The following is a description of a gene set: studied in species Mus musculus Mouse Gene Set: ETV2_TARGET_GENES from publication Yevshin I, Sharipov R, Kolmykov S, Kondrakhin Y, Kolpakov F (PMID 30445619) Genes containing one or more binding sites for (Etv2) in their promoter regions (TSS -1000,+100 bp) as identified by GTRD version 20.06 ChIP-seq harmonization., and this is the list of marker genes: Med18, Gm3364, Serpinf1, Brix1, Necap2, Parp3, Apold1, Gm16046, Rpsa, Ints11 (integrator complex subunit 11), Trip12, Ptges3l, Ebna1bp2 (NCBI Gene Id 97170), Dbt, Sympk, Uso1, Avl9, Snrpb, Ifnar1, Ing4, Tada3, Mier1, Dusp6, Gm26670, Myl12a, Mettl6, Garin1b, Topbp1, Rps6ka2, Fli1, Tln1, Efcab7, Amz2, Mcm8, Vamp3, Fem1a, Scrib, Mettl3, Cog2, Gm16120, Shroom3, 6030443J06Rik, Rnf216, Gm20716, Dnajb6, Prpf19 (pre-mRNA processing factor 19), Psma6, Rab13, Dhx36, Gm12694, Lamtor1, Mcrs1, Gm14010, Dph3, Clca2, Sowahc, Fkbp1a, Zranb2, Tex10, Med30 (NCBI Gene Id 70303), Zfp787, E2f4, Ngrn, Nup214, D330041H03Rik, Mon1b, Mfsd5, Ncbp2as2, Fmc1, Rpl36al, Clint1, Epn1 (NCBI Gene Id 13854), Pomp, Sox17, Oxnad1, Gm16104, AA474408, Pde4b, Vpreb1a, Mgat2, Trappc14, Sec24c, Ppan, Slc38a10, Pin1, Fam204a, 9330151L19Rik, Kcnk2, Dynlrb2, Tank, Ppp4c, 1600012H06Rik, Rab10os, Adprm, Wdr89, Spink10, Synj2bp (NCBI Gene Id 28115), Fam32a, Eaf1, Exd2, Sp2, 6530401F13Rik, Tufm, 2310011J03Rik, Cyb5d2, Slc15a4, Gm38250, Tmem126a, Traf7, Med11, Ypel3, Sirt6, Srd5a3, Mysm1, Sde2, Pex12, Rac1, Birc6, Fndc11, Arpc4, Ptdss1, Chmp5, Nsun5 (NCBI Gene Id 215084), Nelfe, Med17, Nosip, Ddx46, Zbtb45, Creb3, Pofut2, St6galnac3, Arhgap1, Wdr11, Trmo, Gnpat (NCBI Gene Id 51942), Zc3h15, Cds2, Fbxl9, 4933427D14Rik, Dok4, Rrp9 (NCBI Gene Id 27966), Calm3, C230035I16Rik, Kpnb1, Orc5, Atp6v1g2, Zfc3h1, Ndufaf7, Pcdh12, Lrrc75a, Ccdc181, Cass4, Txndc17, Rapgef6, 2810004N23Rik, Gm9828, Dpm1, Mcm7, Pik3r2, BC035044, F2rl3, 1700086O06Rik, Zfp110, Rasgrp3, Gm29328, Mroh8, Pdcd2, Top3b, Dusp3, Asb6, Ube3c, Rnpc3, Trmt11, Zbtb9, Gm15559, Ddx21, Gm1604a, Oard1, Nckap1, Etv2, Gtf2ird2 (NCBI Gene Id 114674), Pigx, Zzef1, Ctsh, Aste1, Sh3bp5, Ccdc51, Ric8a, Stk11ip, Trim41, 1500015A07Rik, 1810041H14Rik, Rraga, 1700054K19Rik, Pih1d2, Ciao2b, Trpm8, Pced1a, 4930592C13Rik, Sec31a, Ppid, Taf12, Exoc3, Zfp113, 4833420G17Rik, Nfkbil1, Lyset, Mrpl57, Prkar1a, Vps16, Pum3, Tatdn1 (TatD DNase domain containing 1), Aurka, C330018D20Rik, Rpl34, Gcc2, Fam124b, Tbc1d15, Ipo11, Copa, Hyal2, Bbs4, Fam110a, Etohd2, Noc3l, Pop7, Srsf7, Rbsn, Spopl, 4930478M09Rik, Fbxl12os, Ift70a2, Cox17, Mogs, Bcap31, Bcl6b, Moap1, Tek, Zfp865, Tlnrd1, Lrrc8a, Thoc5, Junb, Ttc39d, Usp45, Nkiras1, Arl15, Rchy1, Mttp, Rps6, Zfp143, Gm16096, Grpel2, Med10, Mrps16, Sec23ip, 4933417C20Rik, Ssbp1, Slc25a32, Ercc3, Cfap45 (NCBI Gene Id 71870), 2900076A07Rik, Ccnl1, Abcd1, Stk16, Wnt3, Cnrip1, Id3, Use1, Ncbp2, Slx9, Ncstn, Kif3b, Snrpe, Picalm, Yipf3, Col11a2, Gm26535, Ulk4, Myct1, Carf, Dele1, Elavl1 (NCBI Gene Id 97501), Snord15a, Glrx5, Cdk7, Rab11fip4os1, Mesd, Stk40, Gm11454, Cdk20, Ppp1r11, Gmip, Sema6b, Nfya, Prdm4, A330035P11Rik, Zc3hav1, Nsrp1 (NCBI Gene Id 237859), Cebpz, Arb2a (NCBI Gene Id 72538), Lsm5, Tmem154, Tnfrsf9, Hnrnpf, Sh3tc1, Ppp1r10, Pik3ca, Ccdc9, Rars1, Pex6, Gm25541, Nup107, Hjurp, Exoc2, Fth1, Psmd12, Mapk1ip1l, Cnbd2, Ephb4, Atxn7l1, Mmgt2, Hibch, Psen1 (presenilin 1), 2810021J22Rik, Ica1, Trmt10a, Tstd3, Sco1, Ddx18, 9230114K14Rik, Fdx2, Zcchc9, Cdt1, Sbno2, Wdr73, Ywhab, Snrpd3, Qng1, Rpl11, Ddx19b, Rpl37, S2bpcox16, Lrrc41, Smg7, Txnip, Pigm (phosphatidylinositol glycan anchor biosynthesis, class M), Ncdn, Ppm1g, Midn, Zfp558, Lpp, Cant1, Wrap53, Ctla2b, Zfp687, Fbxw2 (NCBI Gene Id 77009), Ndufb9, Catsperg1, Mir8098, Ggnbp1, Cnot10, Tmem229b, Tns2, Rps3 (NCBI Gene Id 52418), Rasip1, Rps27, Cog8, Gm10575, Gm12976, Itpa, Cage1, Gm15518, Ap2b1, Mocs3, Camkmt, Pak1ip1, Zfp407, Chd9, Bola2, Setd4, Crem, Dpm3, Gm26205, Zhx3, Slc9a8, Sugct, Dad1, Fbxl12, Tbpl1, Trib1, Rpn2, Cnr2, Esam, Tnpo3, Wipi2, Gm5447, Jak3, 1700082M22Rik, Coa5, Cltc, Cep41, Zfp7, Zfp57, Skic2, Zfp512, Snhg6 (small nucleolar RNA host gene 6), Zfp175, Psmd2, D5Ertd605e, Foxa3 (NCBI Gene Id 15377), Tmem208, Myl12b, Exoc3l, Tmem131l, Armc7, Atp1b3, Lncenc1, Prkab1, Ube2j2, Utp3, Ssmem1, Zfp623, Dnajc25, Dcaf13, Clta, Tcea1, Mrpl52, Uqcrh, AU040320, Itgb1, 1810014B01Rik, Itprid2, Diaph1, Itpripl2, Dbnl, Klhl6, Ap1b1, Crip2, Nek11, Iscu, Itgb3bp, Rpl27, Dtymk, Shc1, Gm37896, Gm15417, Nkapd1, Gm14167, Cracr2b, Lyrm2, Nmbr, Thap6, Zfp622, Tm9sf2 (transmembrane 9 superfamily member 2), Mir423, Grcc10, Ndufs3, Llph, Zfp105, Serinc5, Gle1, Tjp1, Trmt6, Tbrg4, Ttc9c (tetratricopeptide repeat domain 9C), Fbxo22, Zfp384, Polr1c, Tma7, Zfp24, Nelfb, M6pr, Fdxr, Vta1, Elf2, Tpm3, Tprkb, Tgfbr2, Hmgxb3, Cstf1, Bet1l, Ufm1, Ankrd24, D430040D24Rik, Prrg2, Gm10941, Khdc4, Usp28, Stk4, Ep400, P4hb, Ubac2, Washc1, Cdh5, 1700010I14Rik, Wdfy2, Susd1, Ttpal, Septin10, Pramel12, Mrps18b, Rapgef3os2, Adam17, Kdm5a, Atg16l1, Kcne3, Aim2, Rad1, Gamt, Cfap97d1, 4930405N21Rik, BC043934, Gm6410, Bnip3l, Ttc1, Ppib, Imp3 (IMP3, U3 small nucleolar ribonucleoprotein), Nat8f1, Eapp, Aco2, Isy1, Uba7, Evi5, Cfap57, Txndc5, Ap2a1, Atp6v0d1, Arih2, Gm19721, Eif5a, Tmem94, Emc7, Accs, Nip7, Arap3, Ubl5, 2310010J17Rik, Fhit, Lfng, Isca1, Rps19 (ribosomal protein S19), Idh3b, Tmem198, Btf3, Mterf3, Aggf1, Fubp3, Epha2, Stpg2, Tsr1, Csnk1g1, Mob3c (MOB kinase activator 3C, NCBI Gene Id 100465), Nfx1, Zfp330, Kti12, Tmem209 (transmembrane protein 209), Sptlc2, Glb1l, Cript, Acbd5, Exoc1, Ghdc (NCBI Gene Id 80860), Gm9917, Ywhaz, Phf5a, Zbtb17, Ankhd1, 1700020M21Rik, Vps4b, Slc43a2, Mplkip, Gabpb1, Tbkbp1, Igfbp4, 2410002F23Rik, Shoc2, Zfp568, Chpf, Zfp58, Ppp2r3d, Gale, Usp8, Snx11 (sorting nexin 11), Commd5, Sfr1, Prepl (NCBI Gene Id 77396, prolyl endopeptidase-like), Dnai4, Ttyh3, Rps17, Slc13a1, Arhgap27, Tmem258, F730311O21Rik, Tfam, Zfp408, Gm9967, Dapk3, Clic1, Sys1, Appl2, Cdk1, Gtf3c4, Nol6, Ttll1, Bag1, Gm15441, Rgs3, Gm10433, Cacybp, Grk5, Stat6, Tprg1l, 1700012E03Rik, Ocel1, Spty2d1, Cops7a, Mef2c, Trappc6b, Fen1 (NCBI Gene Id 14156), Fev, Prkag1, Gpatch2l, Ublcp1, Prex1, Tgif2, Gucd1, Champ1, Rhoj, Mrpl1, Rpl15, Cep19, Morn1, Vwf, 4930481B07Rik, Rapgef3, Hhex, Rundc1, Ube2f, 5730471H19Rik, Mirt1, Wdr12, Lhfpl7, Alg12, Tssk6, Nufip2, Cdk12, Med7, Dhx9, Slx1b, Git2, Dguok, Ccar2, Creld2, Keap1, Uba2, Rpl36, 6330418K02Rik, 9930012K11Rik, Akap13, Crlf3, Caprin2, Cap1, Fbxo38, Usf1, Tmem144, Egfl7, Kbtbd4, Rnaseh2b, Bcl2l1, Actb, Trip4, Mus81, Rpl6, Zswim8, Gm27003, Pigf, Mff, Pex2, Abcf1, Rer1, Thap1 (NCBI Gene Id 73754), Ovca2, Thumpd3, Sart3, Urm1, Park7, Abhd4, Kat5, Thap2, Arpc2, Ska3, Ap4m1, Klhl20, Thg1l, Mcl1, Gm13421, Grap, Etv6, BC028528, Secisbp2, Ythdf3, Cptp, Hsp90b1 (heat shock protein 90, beta (Grp94), member 1), Lmna, Tor4a, Pf4, Slc39a13, Unc50, Gm13816, Zfp93, Tial1